Given this list of marker genes Taf6, Hdac3, Taf5, Mnat1, Bcl2, Gnb1, Ccnd1, Ep300, Polr2i, Tbp, Chuk, Crebbp, Akt1, Hras, Gtf2a2, Hdac7, Polr2f, Gtf2h4, Gtf2h3, Polr2g, Hdac1, Brca1, Gper1, Jun, Polr2e, Sos1 (SOS Ras/Rac guanine nucleotide exchange factor 1), Map2k1, Gnas, Elk1, Prkaca, Polr2b, Polr2c, Taf7, Src, Hdac2, Esr1, Ikbkg, Taf13, Gtf2b, Ercc3, Ncor1, Gngt1, Gtf2h2 (general transcription factor II H, polypeptide 2), Ccnh, Hdac6, Grb2, Ilk (integrin linked kinase), Polr2h, Shc2, Cdk7, Creb1, Braf, Hdac4, Taf9, Polr2a (polymerase (RNA) II (DNA directed) polypeptide A), Hdac5, Nfkb1, Polr2k, Mapk9, Mapk1, Ercc2 (NCBI Gene Id 13871), Sin3a, Gtf2f2, Hdac8, Fos, Polr2j, Gtf2e2, Mapk14, Sp1, Gtf2h1, Gtf2e1, Ikbkb, Pik3ca, Ak6, Taf12, here is a description of the gene set: species: Mus musculus Mouse Gene Set: WP_ESTROGEN_SIGNALING Estrogen signaling